Given this list of marker genes SCAPER, GDF10, ESR1 (NCBI Gene Id 2099), GABRB1, NOTCH1, EREG (epiregulin, NCBI Gene Id 2069), NHLH2, FSHB, MMP2, NOTCH4, PTX3, TNFAIP6, GNRH1, OPRK1, SIRT1, PDGFRA, FSHR, CASP3, SLIT3, NR5A2 (NCBI Gene Id 8768), NPR2 (natriuretic peptide receptor 2), ROBO2, TYRO3, MSTN, AFP, PLEKHA1, STAT5B, ZP3, PTN, INHBA, FOXO3, CASP2, FZD4, TGFB3, NPY5R, NPPC, LHCGR, NR5A1, AMH, RETN, BMPR1B, SLIT2, ADAMTS1, CGA, PGR, STAT5A, PTPRN, NCOA1, TGFB2, ZNF830, NCOR2, NRIP1, ADNP, SERPINF1, SGPL1, NOS3, AXL, GPR149, HAS2, CA12, GAS2, EGR1, LEP, MMP19, MDK, GDF9, PCNA, SLC26A6, here is a description of the gene set: studied in species Homo sapiens Human Gene Set: GOBP_OVULATION_CYCLE The type of sexual cycle seen in females, often with physiologic changes in the endometrium that recur at regular intervals during the reproductive years.